The following is a description of a gene set: Human Gene Set: JIANG_MELANOMA_TRM5_CD8 studied in species Homo sapiens from publication Jiang C, Chao CC, Li J, Ge X, Shen A, Jucaud V, Cheng C, Shen X (PMID 38455971) Tissue-resident memory T cells (TRM) are a specialized T cell population residing in peripheral tissues. The presence and potential impact of TRM in the tumor immune microenvironment (TIME) remain to be elucidated. Here, we systematically investigated the relationship between TRM and melanoma TIME based on multiple clinical single-cell RNA-seq datasets and developed signatures indicative of TRM infiltration. TRM infiltration is associated with longer overall survival and abundance of T cells, NK cells, M1 macrophages, and memory B cells in the TIME. A 22-gene TRM derived risk score was further developed to effectively classify patients into low- and high-risk categories, distinguishing overall survival and immune activation, particularly in T cell-mediated responses. Altogether, our analysis suggests that TRM abundance is associated with melanoma TIME activation and patient survival, and the TRM-based machine learning model can potentially predict prognosis in melanoma patients., and this is the list of marker genes: BRD2, IFNGR1, ORAI1, EIF1, ODC1, CTSW, IL2RB, RGS2, STK17B, IER5, CAPG, LY6G5B, EIF4A1, SERTAD1, NFKBIA, SAMSN1, ANXA2, KLF10, UBA52, LRRC58, DUSP1, ZFP36L2, FKBP2, WSB1, SQSTM1 (NCBI Gene Id 94002), BHLHE40, YWHAZ, TBX21 (T-box transcription factor 21), TOMM6, B4GALT1, CD40LG, MYH9, LMNA, BTG1, IFNAR1, CCL4, FGL2, IFNG, SAP18, FOSB, TUBA4A, WBP1, CAPNS1 (calpain small subunit 1), FUS, PHLDA1, PTP4A1, TOB1, MXD4, HSPA5, VGLL4, HSP90AB1, IL21R, DYNLL1, ICOS, RSRC2, ATP2B1, CD69, RORA, GCH1, RRAD (RRAD, Ras related glycolysis inhibitor and calcium channel regulator), PFN1, PPP1R16B, THY1, EMC10, CCDC107, TESC, RAPGEF6, CD6, TNFAIP3, CREM, GEM, EIF5A, KLF6, NFKBID, UBE2S, TGIF1, GPR132, H3-3B, EMD, CHD4, PDIA3, HIVEP2, PDCD1, SIT1, COQ10B, HERPUD1, QPCT, PRR7, ATF3, DUSP5, UBC, RPL15, ICAM1, TAGAP, AKAP13, MALAT1, GSTP1, ACTB, ZFP36, ZFP36L1, YBX1, JUND, SLC3A2, PPP1R15A, FTL, ITM2B, NEURL3, TGFB1, ZNRF1, GNB1, PIM1, VPS37B, WNK1, PNRC1, RGCC, ARID5A, FOS, GADD45B, ETS1, RHEB, RPL35, USP50 (NCBI Gene Id 373509), NR4A3, NDFIP1, TMEM256, ENO1, HSPA8, DNAJB1 (DnaJ heat shock protein family (Hsp40) member B1), MIF, CD44, BTG2, PRKAR1A, NFKBIZ, ITK, RGS1, GAPDH, SLC38A2, SOCS1, HSP90B1, LDHA, SMAD7, CCND2, PTMA, CD82, NR4A1, CISH, IL2, HILPDA, ALDOA, POLR2L, CITED2, COTL1, LITAF (lipopolysaccharide induced TNF factor), LCP1, SMCO4, JUNB, CSRNP1, CALM1, FTH1, PDIA6, ITGAE, CLK1, HSD11B1, SLBP, CDKN1A, IL2RG, PPP1R11, ZC3H12A, FOSL2, PLD3 (phospholipase D family member 3), NR4A2, PKM, IER2, ANXA1, CALM2, PTPN22, TNFAIP8, KDM6B, HMGN1, TMEM123, ITPKB, IFRD1, SAT1, DNAJA1, PRDX6, SRSF2, CD28, ATP5MK, NR3C1